The following is a description of a gene set: An abnormality of the stomach. Human Gene Set: HP_ABNORMAL_STOMACH_MORPHOLOGY studied in species Homo sapiens Abnormal stomach morphology, and this is the list of marker genes: IGKC, CAMTA1, OSGEP, CAVIN1 (caveolae associated protein 1), PEX2, YRDC, RTL1, WFS1, PEX14, MYH11, BAZ1B, RIPK1, TBL2, BMPR1A, PDGFRA, PEX1, TBX3, HDAC4, PEX12 (peroxisomal biogenesis factor 12), LIMK1, NFKB2, MCC, RYR1, ACD (NCBI Gene Id 82538), CHEK2, ATP6V1E1, ALDH18A1, KRAS, AKT1, BRAF (B-Raf proto-oncogene, serine/threonine kinase), AIRE, SPEN, CHD8, FOXP3, DLK1, SRC, NFKB1, DHCR7, FBLN5, ERBB2, BUB1, COL5A2, GLRA1, EIF4H, SKIC2, BCL10, RPS20, NCF4, CTLA4, PIK3CA, ELN, PTCH1, LRBA, COL5A1, CHST14, TRAF7 (TNF receptor associated factor 7), ATP7A, ERMARD, IFIH1, PMS1, LAMC2 (laminin subunit gamma 2), MGMT, EFEMP2, BUB3, PEX3, PEX19, FAS, ATAD1, TMEM270, CASP10, TCF4, APC, CYBA, TP53, TFAP2A, DYRK1A, NUP107, CBLIF, ELF4, TMTC3, ADAMTS3, EPCAM, DEF6, GLRB, MMP23B, LAMA3, VPS37D, MLH3, SERPINA1, TLR2, CARD8, NEK9, CYBB, FAT4, KIT, COL18A1, SMC1A, RAD21, DHODH, UBE4B, FLCN, PDE11A, PIEZO2, EXT2, CDK4, RNF43, DNAJC30, PDGFRL, PEX11B, MSH6, HSPG2, ZEB2 (NCBI Gene Id 9839), IGHG2, ARFGEF2, SDHA, FKBP6, COL14A1, NRAS, SKIC3, VAC14, BLM, KANSL1, BAP1, GALE, MTMR14, POT1, ADAMTS2, FLNA, ARF1, SKI, MYF6, GON7, TGFB3, LAGE3, CISD2, CEP57, PYCR1, GABRD, ATM, RFC2, STS, PRDM16, SLC6A5, POLD1, STX1A, BUD23, TAF6, MTM1, LAMB3, EP300, MUTYH, FOCAD, PLA2G2A, CCND1, SYT2, MAP3K7, ITGA6, PEX6, GTF2IRD2, METTL27, SYK, BIN1, GLIS3, IRF1, DNM2, ARID1B, PEX10, CCBE1, NAA10, SDHC, MC1R, SMAD4, NPHS1, CYBC1, CLIP2, BUB1B, MSH3, WDR73, GTF2H5, MAPK1, HDAC8 (histone deacetylase 8), PLEC, STAT3, IL1B, TGFBR2, MAP1B, TERF2IP, NIPBL, PPP2R3C, COL1A1, WDR4, MEG3, PLA2G4A, FIG4, MDM2, PEX13, KLF6, SERPINH1, AAGAB, PTPRJ, SH2B1, CRKL, GBA1, GTF2I (NCBI Gene Id 90875), NCF2, AURKA, PEX5, SDHB, CASZ1, ENG, MED12, NEDD4L, ADAMTSL2, PMS2, TERT, ITGB4, GPHN, TPRKB, C1R, STK11, SLC2A10, SMC3, NCF1, IPO8, PRKAR1A, TRIP13, POLE, FASLG, HRAS, BCR, HNF1B, PTPN12, PORCN, BCOR, BRD4, FGFR3, MLH1, LUZP1, RERE, NEFH, LTBP1, BAX, ZBTB7A, AXIN2, TREX1, FLI1, RAD54B, CDKN2A (cyclin dependent kinase inhibitor 2A), PEX26, PDPN, BRCA2, PPP2R5D, MSH2, TNXB, NUP133, PRKCZ, DLC1, IL1RN, LBR, GTF2IRD1, DCC, ABCC2, KCNAB2, LTBP4, ZNF699, CDKN2B, CDH1, EFEMP1, CTNNB1, ZFX, PEX16, NFIX, TP53RK, MITF, PAK2, SEMA4A, FGFR2